Given this list of marker genes Cobl, Pfn1, Fam98a (NCBI Gene Id 72722, family with sequence similarity 98, member A), Nlgn1, Plekhm1, P2ry12, Def8, Rac1, Ndel1, Eps8l2, Eps8l1, Cyfip1, Hras, Mtor, Eps8l3, Eps8, Carmil2, here is a description of the gene set: Any process that activates or increases the frequency, rate or extent of ruffle assembly. species: Mus musculus Mouse Gene Set: GOBP_POSITIVE_REGULATION_OF_RUFFLE_ASSEMBLY